Given this list of marker genes Bmpr1a (bone morphogenetic protein receptor, type 1A), Dmrta2 (doublesex and mab-3 related transcription factor like family A2), Sfrp2 (secreted frizzled-related protein 2), Sox9, Sox17, Sox18, Gsc, here is a description of the gene set: Mouse Gene Set: GOBP_STEM_CELL_FATE_SPECIFICATION The process in which a cell becomes capable of differentiating autonomously into a stem cell in an environment that is neutral with respect to the developmental pathway. Upon specification, the cell fate can be reversed. studied in species Mus musculus